Given this list of marker genes RAC2, ARPC2, FRMD7, MSTN, NCKAP1, AVIL, CARMIL1, AUTS2, PLCE1, WNT1 (NCBI Gene Id 7471), CORO1C, CYFIP1, TWF2, HSP90AA1, PIK3R1, RREB1, WASF2, MTOR, ARHGEF7, VIL1, ACTR3, SRC, CLRN1, OCLN, CARMIL2, BRK1, RAC1, PIK3CA, FSCN1, CORO1B, ENPP2, ABI2, CFL1, ACTR2, CDC42, AKIRIN1, here is a description of the gene set: species: Homo sapiens Any process that activates or increases the frequency, rate or extent of lamellipodium organization. Human Gene Set: GOBP_POSITIVE_REGULATION_OF_LAMELLIPODIUM_ORGANIZATION